Given this list of marker genes MAP2K2, MBTPS2, ZBTB20, AARS1, PKP1, ITGB4, CARS1, RETREG1, KRAS, SCN9A, HPGD, TARS1, BRAF, ERCC3, LMNA, RUNX2, HLA-B, KIF1A, MPLKIP, WNK1, RNF113A, COL7A1, MAP2K1, WNT10A, NECTIN1, ERCC2, KRT74, ZMPSTE24, STAT3, COL17A1, GTF2H5 (NCBI Gene Id 404672), GTF2E2, here is a description of the gene set: studied in species Homo sapiens Human Gene Set: HP_DYSTROPHIC_FINGERNAILS The presence of misshapen or partially destroyed nail plates, often with accumulation of soft, yellow keratin between the dystrophic nail plate and nail bed, resulting in elevation of the nail plate. Dystrophic fingernails